The following is a description of a gene set: Mouse Gene Set: GOBP_MICROTUBULE_ORGANIZING_CENTER_LOCALIZATION studied in species Mus musculus Any process in which the microtubule organizing center is transported to, and/or maintained in, a specific location within the cell., and this is the list of marker genes: Ezr, Dlg1, Pard3b, Syne2, Syne1, Ndel1, Mad2l1, Nin, Akap9, Fhod1, Ints13, Bicd2, Nubp1, Sun2, Arpc5, Tbccd1, Ccdc141, Ranbp2, Misp, Aspm, Aurka, Nde1, Pard3, Sema6a, Pkhd1, Gpsm2, Kif5b, Cep83, Dlgap5 (DLG associated protein 5), Dync1li2 (dynein, cytoplasmic 1 light intermediate chain 2), Ift20, Tmem201, Sun1, Spout1, Plxna2, Pafah1b1 (platelet-activating factor acetylhydrolase, isoform 1b, subunit 1)